The following is a description of a gene set: species: Homo sapiens Genes down-regulated in thymocytes: double negative versus double positive. T cells develop from progenitors that migrate from the bone marrow into the thymus. Thymocytes are subdivided roughly as being double negative (DN), double positive (DP), or single positive (SP), based on the expression of the CD4 and CD8 coreceptors. The DN stage is heterogeneous and can be subdivided into four distinct subsets in mice based on the expression of CD44 and CD25. In human, three distinct DN stages can be recognized: a CD34+CD38−CD1a− stage that represents the most immature thymic subset and the consecutive CD34+CD38+CD1a− and CD34+CD38+CD1a+ stages. Human DN thymocytes mature via an immature single positive (ISP CD4+) and a DP stage into CD4+ or CD8+ SP T cells that express functional T cell receptors (TCR) and that exit the thymus. In this study, gene expression was measured in each of these nine stages. from publication Dik WA, Pike-Overzet K, Weerkamp F, de Ridder D, de Haas EF, Baert MR, van der Spek P, Koster EE, Reinders MJ, van Dongen JJ, Langerak AW, Staal FJ (PMID 15928199) Human Gene Set: GSE22601_DOUBLE_NEGATIVE_VS_DOUBLE_POSITIVE_THYMOCYTE_DN, and this is the list of marker genes: ERMN, GMPPB, SENP7 (NCBI Gene Id 57337), GDI1, TNFRSF25, TIMM10, ETF1, MITD1, CPM, GIMAP8, UBE2D3, EIF3K, UBA7, MFAP1, ATP10A, GLTP (glycolipid transfer protein), STAT3, PPP1R12A, YRDC, DOCK2, SLC25A33, MPHOSPH10, TRAM1, SH2D1A, DPP4, PITPNA, CPE, FBXO9, SON, FAM32A, CRLF2, SEC16A, G3BP2, IRAK3, RAB18, AGER, PLEKHA3, ATP6V1H, CD160, TRAPPC14, UBA3, TBC1D1, CEBPZ (NCBI Gene Id 10153), GNPDA2, CRYBG1, AZI2, PREB, LPCAT3, PPM1K, PLIN3, CALCRL, PPIL4 (peptidylprolyl isomerase like 4), UGGT1, BCCIP, INPP1, KCTD12, SLC35B1, STAT4, SENP3, PDE2A, SELL, RASA3, UBASH3B, TCF7, PIK3C2A, EIF4E3, WDR45B, MBD2, TNS4, SLC39A1 (solute carrier family 39 member 1), PATZ1, ST3GAL4, DCUN1D4, SDAD1, GINM1 (NCBI Gene Id 116254), MMGT1, HLX, RUNDC1, UBE2G2, FBXO17, CREBRF, TRAPPC2L (NCBI Gene Id 51693), YWHAZ, SRM, ANKRD13A, DAAM1, PHF20L1, KLRC1, ASXL2, ESYT1, PCMTD2, UBAC2, ALG3, KTI12, DMTF1, RBMS2, UNC45A, IGFLR1, ITPKB, PDIA6, RAB21, CRK, DIAPH2, UPF2, SATB1, ITGB3, ENTR1, C3orf38, SLC25A23, PRKAR2A, TMEM176A, TRAPPC8, TBRG4, FRAT2, CACNB2, HSPH1, SNX10, DGKA, KLRD1, PPTC7, ERN1, AFF4, UBE2H, GDAP2, RHOBTB2, IAH1, MCTP2, EXOC6, KBTBD8, ATF6, GPBP1L1, S1PR4, TMEM223, USP12, GSK3A, P2RY14, PLEKHG2, CHFR, TRPC4AP, RFK, CLTB (NCBI Gene Id 1212), HPS3, FAM8A1, CDKN2D, MPI, RBM33, PPM1J, ASB6, PTPRE (NCBI Gene Id 5791), CD200R1, SNAP23, AKAP8L, PRR14, SLC35G1, GNL3, STIM2, RNF146, SEC63, UIMC1, BAZ1A, NMD3 (NMD3 ribosome export adaptor), CIB1 (NCBI Gene Id 10519), ARHGAP30, GPR155, ST6GAL1, GATA1, IL2, DDX3Y, HBP1, VPS4B, AIMP2, CHMP1B, MAML1, C16orf54, SEC24A (NCBI Gene Id 10802), PEDS1, GIMAP4, CCNL1, SPNS1, CASP1, TRPM4, INPP5A, PPA1, CAPN2, SEC13, BLTP3B, CARD6, TGM2, BAZ2A, ALKBH1, SIRT2, NARF, IDH3A, RELCH, RBFA, COQ10B, CEBPB, PRKACB, EIF2AK1, CYB5A